Given this list of marker genes PROZ, BGLAP (NCBI Gene Id 632), F9, GGCX, F7, PROS1, PROC, F2, F10, GAS6, FURIN, here is a description of the gene set: Gamma-carboxylation, transport, and amino-terminal cleavage of proteins Human Gene Set: REACTOME_GAMMA_CARBOXYLATION_TRANSPORT_AND_AMINO_TERMINAL_CLEAVAGE_OF_PROTEINS studied in species Homo sapiens